The following is a description of a gene set: Genes containing one or more binding sites for (ZNF22) in their promoter regions (TSS -1000,+100 bp) as identified by GTRD version 20.06 ChIP-seq harmonization. studied in species Homo sapiens Human Gene Set: ZNF22_TARGET_GENES from publication Yevshin I, Sharipov R, Kolmykov S, Kondrakhin Y, Kolpakov F (PMID 30445619), and this is the list of marker genes: S100A2, CDH12, TPTEP2, LINC02202, SMG8, RN7SL3, ZNF419, S100PBP, PHF7, ZNF763, PTCD1, POLR3A, MT-TV, MELK, AHI1, ZNF177, CPNE1, FAM234A, DNAH14, PRR13 (proline rich 13), MT1XP1, MIR6728 (microRNA 6728), MIR4714, RBCK1, TBC1D5, RNU2-22P, MRGPRD, MIIP, OASL, UTP11, RAB26, ENSG00000224865, TRIP12, RFWD3, MAP2K5, EMX2, PUM1, MFSD2A, AHSA1, AGFG2, MIR6797, DOCK5, WFDC3 (WAP four-disulfide core domain 3), KLC4, RNA5SP492 (RNA, 5S ribosomal pseudogene 492), RPS14, RNU2-2P, GABARAP, SLC9A1, FBXL8, ATG10, MTND4LP12, SAXO5, UBE2V2P4, EMX2OS, RNU6-135P, DST, RRAS2P2, UQCRFS1 (ubiquinol-cytochrome c reductase, Rieske iron-sulfur polypeptide 1), MAPK14, IGDCC3, TNKS, PI16, ARHGAP25, KLHDC10, PPIP5K2, SGSM3, TNRC6A, LBR, CHMP6, KPNA7, ABCD4, HNRNPU, VDAC1P5, TNFRSF9, CHRNA2, RNA5SP97, ITGA8, ZNF433, GANC, RNU6-284P, COMMD4, ABCA8, KRT17P7, TPTE2P5, FLYWCH2, SERTAD4BP, C3orf62, MARS1, MICAL3, MPPE1, PRRG1, NEIL3, CLASP1, MYO19, DNAJC11, NBPF1, RPL13P4, MTRFR, CYTH1, C1orf127, TMEM14C, CYP1D1P, SLC41A2, EHMT2, HIGD2B, CELF5, SLC25A16, OSBPL8, POLR2F, XIAP, LINC02713, RPL17P47, PTCH1, CNTNAP2, TRIM23, BAX, ECT2L, EIF1AD (eukaryotic translation initiation factor 1A domain containing), LINC02185, MX2, REPS2, GATAD2B (NCBI Gene Id 57459), FOXP2 (forkhead box P2), NBEAL1, TSEN15, E2F2, CLN3, CRYZL1, FLOT1, LINC00528, EML6, LDHB, CCDC107, TIMM9, SLC25A27, LINC01766, BCL6, NR2F1, MTCO3P12, TMEM248, LINC00173, ZNF575, MAP1LC3BP1, TAF13, MFF, JPX, ETFBKMT, RPL3, MRPL36P1, RNU6-1233P, OAT, RPL7P46, CLIP2, DNAJB6, ABCA15P, MYB, TAAR5, ACTMAP, HAX1 (HCLS1 associated protein X-1), ATF7IP, RNU6-66P, GSTZ1, PKMYT1, ARHGAP17, PDE1B, ATP6V0A1, CREB3L4, TPH2, ASCC2, UBE2V1P15, EIF1AXP1, CTXND1, TACO1, ZCCHC8, EP400P1, RN7SL341P, ENSG00000262003, CFAP299, FBXW4, LINC02281, ATG13, LPP, RWDD2B, ERN2, TLR5, HMGA1P3, CCNB3 (cyclin B3), SPATS2, TMEM200A, DDX10, RNU6-199P, LINC00092, CR1L, COX6B1, ZNF295-AS1, TRAF4, PRICKLE1, LINC01926, RPS5, NFYC, ASH1L-IT1, CRYGD, NAV1, RPSA, NSL1, CCDC18-AS1, PLEKHO1, TLE2, INE1, DHRS3, TICRR, ACIN1 (NCBI Gene Id 22985), PPP1R12B, ADAMTS16-DT, UBASH3B, DYNC2LI1, TRIM11, NTNG1, ZDHHC17, APH1B, DPM3, ANXA2, IGSF9B, DCBLD1, SLX9, RNU6-1248P, SPPL2A, USP6NL-AS1 (USP6NL antisense RNA 1), MIR4477A, METTL2B, FZD9, FANCD2, SNRPD1, GON4L, EREG, TAF3, NOSTRIN, STING1, FIG4, NFKBID, RNU6-486P, LRWD1, LRRFIP1, GMPR, MUC19 (NCBI Gene Id 730517), GAS1RR, RN7SL180P, FRMD3, NVL, KATNA1, MAST1, PLXDC1, OR10G2, USP45, MRPL1, RNU6-809P, KIF23, GPATCH1, ODF2, RPS23P8, COQ9, SLC25A13, HSP90B1, YAF2, CHPT1, MPZ, ARHGEF7, PTGR1, SNAP47, KPNA6, TOP3A, RPS4X, ZNF382, CDIPT, PYDC1, RPL8, RPL26L1, INTS7, DOCK2, LINC01758, STAT6, TRAPPC2, DCTN6, NUGGC, KDM3B, USP9X, ENSG00000251126, MROH7, NCOA6, NUS1, EBF1, SNORD36B, TATDN3, IRAK4, LNCPRESS1, PRMT9, SRRM1, PPCDC, CDIPTOSP, H3C12, POLB, MORF4L2, LINC02601, INTS14, UTP18, PSMA5, EML5, MACF1, VPS51, GABRR1 (gamma-aminobutyric acid type A receptor subunit rho1), RN7SKP106, LINC02865, PPARA, FKBP10, NDUFS7, TMPOP2, IRGC, CYFIP2, SUZ12P1, ING3, HMGXB4, UBAC2, OSTCP1 (oligosaccharyltransferase complex subunit pseudogene 1), GLUD1P3, SPMIP10, RPS2P44, ATP6V0A2, A2ML1, TRAPPC13, ENDOG, ARHGEF38, EIF3J, GMNC, RPL35AP17, PAGR1, SLC35B1, TRDMT1, CELF1, H2AC17, OSBPL1A, RSRP1, OR6C75, RNU6-1, RNU6-271P, SYTL1 (synaptotagmin like 1), STMP1, P2RX4, MFN1, RN7SL40P, SLC16A1 (NCBI Gene Id 6566), SRP72P2, CAMTA2-AS1 (NCBI Gene Id 101927979), GPM6A (NCBI Gene Id 2823), CALD1, FLCN, F3, ACP6, MLIP, RN7SL67P, LINC01455, CCNC, FRMD4A, FDX1P1, C6orf52 (chromosome 6 open reading frame 52), SNHG11, NIFK-AS1, ADGRE1, PTK2B, RNU6-658P, CCSAP, ANAPC5, RNU6-760P, RC3H1, EPCIP-AS1, HOOK2, ENSG00000272195, ZNF256, ENSG00000263594, DIPK1A, H4C8, ZNF724, FCGR2A, ELF1, PDE4D, SNORD4B, TJAP1, SNORD114-19, HARBI1, CHMP4C, LINC02933, ATP5MK, PIK3R1, EVA1A, RPA2, PDCD5, KIF2C, WDR7, ABI2, LINC01547, SAFB2, FAM227B, MYNN, TPTE2, FEZF1, NLGN1, HMGN1P4, ODF4, NUCKS1, TPRG1LP1, RNU6-407P, SELENOK, GLT1D1, MPP2, CHCT1, SSBP1, ZCCHC7, NUDCD3, CDC25C, HNRNPCP9, LY6G6F, TFR2, GIT2, EML2, DNTTIP1, LINC02608, REXO4, KRT8P43, AGPAT3, NECTIN3, C19orf44, ARGLU1, LYSMD1, ZNF624, POLR1B, SNORD36A, STAG2, ITPR2 (NCBI Gene Id 3709), SKOR1-AS1 (SKOR1 antisense RNA 1), TMEM260, MT-ND4L, ZNF217, BMI1, SAT1 (NCBI Gene Id 6303), RNU6-1011P, NAGPA, RPPH1, ESRRB, SCAMP3, TEX41, HPGD, VPS53, LINC00910, TGFBR3, LYRM9, MATR3, PGRMC2, SNORD99, PLK3, SAMSN1-AS1, NR2F2-AS1, LINC01841, OR11H4, RNU6-892P, BYSL, PHLDB3, PRC1-AS1, ZEB2, PSMB10, ASB3, F5, CLTC, ZNF146, MTO1, TCF7L2, MICAL2, HNRNPH1, OPN5, LRRC3, SEPTIN2, DTD1, LRCH3, CHMP2B, LINC02219, RBM39, SIRPB2, EGFL6, SH3TC2, RPL23AP35, LCA5, LSM14A, DOCK4, ABCB11, CYCSP27 (CYCS pseudogene 27), SKIDA1, MAD1L1, LINC01596, ZNF438, TRAPPC12, VN1R20P, TADA2A, INO80D-AS1, ERICH6-AS1, ARPC3, SNHG30, VSIG10, MIR5002, LINC02371, COX6B1P2, PXMP4, DOCK7 (dedicator of cytokinesis 7), CFAP53P1, DLGAP2, AKT2, BCL11A, LIN7B, ATP5MF, SPOP, AFF4-DT, MDM1, IGLV2-8, CORO1B, BPHL, ZNF207, CACNA1A, RNF43, C17orf100, EHMT1, FUT3, FAAHP1, PIGV, ETFA, KIF21A, HNRNPD, NKAIN1, PCBD2, MIA2, TTN-AS1, CARD10, FAXDC2, EPM2A, NRP1 (neuropilin 1), H2BC11, GOLGA2P4, DNM1L (dynamin 1 like), ACSM2A, TXN2, SSBL4P, FXYD3, RNU6-375P (NCBI Gene Id 106480575), TMEM91, PSMC3IP, POLR1HASP, SNORA38, SYNM, FEZF1-AS1, F10-AS1, TAFA1, ANKUB1, STPG1, GLO1, CCDC12, RPL7A, RPS15AP29, ENOX1, GPX4, ZNF664, ST3GAL6, PLAUR, CLINT1, CRIP1P4, TPT1-AS1, SF3B4P1, KCNH5, TMEM131L, PRKCQ-AS1, DARS2, RN7SL654P, IQCE, CARM1, ADAM19, ENSG00000248367, TIAM2, CSN1S2AP, SLC7A1, CAMSAP1, GPATCH3, C20orf96, ELP3, RNU4-21P, COQ7, DNHD1, CCDC138, ADAR, ABCB10, PMM1, PDLIM2, SETDB2, HELZ, LRRIQ1, ZNF131, MIA3, ERICH6, GPLD1, ARID5A, PGAP1, USP18, GLS2, ENSG00000253205, ENSG00000255462 (novel transcript), ANPEP, FOXP1, ACLY (NCBI Gene Id 47), ANKRD39, SMIM10L1, SDCBP, SNORD42A, RPSAP53, RFXAP (regulatory factor X associated protein), TDRD9, FGD4 (FYVE, RhoGEF and PH domain containing 4), ZNF544, SLC25A30, NAALADL2, MTHFD1L, TCF20, B4GALNT2, ADI1P3, DPY19L4P2, WAC (WW domain containing adaptor with coiled-coil, NCBI Gene Id 55468), DMGDH (dimethylglycine dehydrogenase), CAPNS1, NSRP1, CHD1, GDF5 (growth differentiation factor 5), FAM174B, TMC5, FAM193A, IFI27L2, GOLM2P1, FAM177B, RNU7-65P, RPL32P26, TRGVA, TYK2, LINC02269, GSTA4, NEMF, OTOL1, TTLL13, LINC00844, PDK4-AS1, COQ2, COL12A1, SLC39A1, MAP3K7CL, MAGOH2P, GLRX5, RPL21P64, RPGRIP1, KLHL32, SNHG4, PPFIA1, MIRLET7BHG, SLC20A2, ZNF428, SULF1, PRR5L, SQSTM1, COLGALT2, RPL36AP45, TSPAN12, FAM217B, USP39, LINC01471, NAB1, TAGAP, CDH10, H3C1, EHBP1-AS1, RUFY1, HSPE1P2 (NCBI Gene Id 326300), SMG5, AAR2, FSTL4, PRPF40B, SDCCAG8, METTL5P2 (NCBI Gene Id 100419878), SEM1, RCN1P2, LTBP4, AKR1B1P2, PPP1R2P6, RPS29, RPL23A, GOLGA7B-DT, LEMD1-AS1, KCTD5, TCEA1P2, ALG1, TFCP2, UGP2, SHLD3, ADRA1A, ZNF57, SLC4A8, ACVR2A, SIRPD, WDR36, TMCO4, RPL21P128, NAA25, CDH7, NABP1, PAK1, ENSG00000229425, FAM47B, TENT2, RPS27L, TMTC1, SKIC8, LCA5L, LINC01842, LINC01553, ABR, MKNK2, DPYSL3, EEF1A1P49, GPRC5A, SFRP4, CDC42EP1, PON2, AP3B1, RBM25, RPL36AP37, UQCC6, UBE3A, CCDC163 (CCDC163 homolog), ENSG00000187951, SMG6, ATG4C, WDR89, RBMS2, DHX29, DONSON, MIER3, LLGL2, SULT1A1, SEC11A, AGFG1, LUC7L2, SPATA1, MATN4, IYD, ADK, ZBTB21, ANTKMT (NCBI Gene Id 82377), CCNE1, MBNL1-AS1, SLC25A3, PARP2, RPSAP10, SPATA6, GTDC1, GMFB, NPDC1, MT-RNR2, ZNF236, PER1, NBR1, TAF15, IFNA21, ZCCHC2, YIPF6, SERPINF1, TWSG1-DT, ULK2, RBM7, CRYBG2, LGALS8, TIMM8A, OGFRL1, ZNF677, LINC00680, SPAG9, SLC9A6, SENP7, SEC14L1, PRMT6, ARHGAP45, TMEM59, GNAS, RB1, RACK1, TCL6, SLC7A2, RPL32P3, DAB1-AS1, CHL1, ATP6V0E1P4, ZBTB8B (zinc finger and BTB domain containing 8B), SERPINB8P1, LRIG1 (NCBI Gene Id 26018), BANF1, NUP188, KRBA2, EN1, AKAP12, GAS2L3, RPL13AP2, FOXJ2, PMS2P3, NT5M, MZF1, ENSG00000259118, WDFY3, GPR85, TBKBP1, HHAT, MTCYBP43, BEGAIN, PCNX2, YDJC, TNNT1, GPBP1L1, VPS33A, RNU6-15P, RN7SL183P, LMAN1 (NCBI Gene Id 3998), MIR4795, ZNF605, SRP14, SYT11, MKI67, SNX8, GAPDHP43, RNA5SP287, IGFLR1, UCK2 (NCBI Gene Id 7371), AASDHPPT, B3GNT8, PDCD6P1, SRP68, RN7SL678P, DGLUCY, FBXO46, PKN3, VPS8, RNASEH1P2, ARRB2, MYDGF, MTMR1, WDR74, SNORD14E, MRPL9, YARS1, ERVK13-1, HCFC2, VPS11-DT, ITPRID2, SMU1P1, CUTC, UBE2D2, GCLM, FSCN1, NEGR1, C17orf75, RMND5A, TXNRD2, NKX2-5, DARS1-AS1, SIRT6, IGLV7-46, COPS4, PMCH, NFKB1, FAHD1, RPL39L, ATF7IP2, LONP2, LINC02351, CRYZP1, MTND5P11, GPR18, CEACAMP8, ZBTB22, MACROH2A1, LINC01121, PFAS, SAPCD2, CASP9, RPS27AP8, GBA1, AGPAT4, SCARNA7, SLC8B1 (solute carrier family 8 member B1), LINC02675, ZMYND19, MSI2, FBXW9, RPL7L1P12 (RPL7L1 pseudogene 12), TBL1XR1, GARNL3, NUP214, SLC7A8, DNASE1, ZNF224, NAPSA, RNU6-41P, ANKRD23, OR5A1, CP, NCSTNP1, RHOQ (NCBI Gene Id 56679), MAP2K6, DHX36, PCBP1-AS1, DOC2A, SMARCC2, SMAD7, RPL29P8 (ribosomal protein L29 pseudogene 8), CTNND1 (catenin delta 1), IPPKP1, MDH1, NT5DC1, TASOR (NCBI Gene Id 51687), MLLT10, SEMA3A (NCBI Gene Id 63232), SLITRK4 (SLIT and NTRK like family member 4), GARRE1, SPPL3, ELAC1, ZSWIM4, CHMP4BP1, BCLAF1, TMEM139, DNAH11, RERE, UGT2B4, MSTN, SUGT1P3, TRMT10B, GPR160, SNORD37 (small nucleolar RNA, C/D box 37), CBFA2T2, WDR54, JTBP1, GAS1, STK36, MYG1, ZNF696 (NCBI Gene Id 79943), LINC02828, SHROOM3-AS1, IL16, PF4, RPL26, SNORD36C, BCAS2P1, PRR14, SLC25A5P7, RNF217, EIF4E, SIN3B, TIMM44, RPSAP54, ENSG00000228919, SCARNA20, LCORL, SAR1A, CAMKK2, IDH3A, HOXB3, GTF3C1, ATP6V1E2, TNFRSF13C, PSMA6, IFIT6P, ZNF284, MAPK8IP3-AS1, PLCG1-AS1, UNKL, PDCD10, SYNE1, ABCA5, XPO6, LINC01649, LRRC27, LINC01058, DCDC2, MEIS1, COQ3, LHX8, ISLR, MVP, TCTN1, CSNK1A1P1, CYP2F1, ATP5MF-PTCD1, YY1P1, ZNF846, MT-ND4, LINC00242, DGKE, KLHL12, CMBL, HMGN2P4, BMPR1B, PIK3IP1 (NCBI Gene Id 113791), RPUSD2, RPL21P10 (ribosomal protein L21 pseudogene 10), RTRAFP1, IL2RA, GOSR1, SCYL2, SNHG8, PKIG (NCBI Gene Id 11142), PHF21A, PIGL, ABCG5, OAZ2, IGHVIII-5-1, CDK12, UBAP2, HSP90AA1, SEL1L3, WDR76, KALRN (NCBI Gene Id 8997), APOL5, STIP1, SCN3A, KRT19, HLCS, PRC1, COX6A1 (cytochrome c oxidase subunit 6A1), CEP83, BBS1, RPS15AP13, DAPK1, CARHSP1, FAM230G, RNU6-558P, MAPK9, DLG1, SERPINE3, ALG10, USP54, KDM2B, RPL17P36, RNY1P10 (RNY1 pseudogene 10), EEF2, HAGH, MIR6747, DIP2C, DOLK, MIR5582, RNU6-395P (RNA, U6 small nuclear 395, pseudogene), LINGO3, RPL7P54, DEUP1, SEPTIN7P1, TMEM150C, SUSD5, PSG11, GPR19, ENSG00000250075, UBR1, POT1 (protection of telomeres 1), SCNM1, TCF4, RPL29P27, MORF4L2-AS1, AURKC, H2AC25, USE1, ZNF689, RALGPS2, PAXBP1, AMZ2, ZMYM6 (NCBI Gene Id 9204), E2F6P4, SNORD114-29, MTND3P9, TMT1A, CTNNA1, PTPRG (NCBI Gene Id 5793), GRM7, SOCS2, IQGAP2, NMB, DNAJC2, SCUBE3-AS1, SEZ6L2, RENBP, MEF2C-AS1, LINC02028, ANKRD20A5P (NCBI Gene Id 440482), ABCC4, LINC02236 (long intergenic non-protein coding RNA 2236, NCBI Gene Id 109729133), CREM, MS4A6A, DEK, PLBD2, JMJD4, MYBPC1, SLC27A2, ERG, MAST2, RABL6, SUPT5H (SPT5 homolog, DSIF elongation factor subunit), RNA5SP321, ADCY10, SNORA73B, CCT8L1P, FAM177A1, METAP1D, LGALS3BP (NCBI Gene Id 3959), LY6G6F-LY6G6D, SPINT1-AS1, SPRED2, GARIN1B, VPS72, COQ5, THUMPD3, RPS7, RERGL, HMGCL, LINC01029, MSX2, YLPM1, NRCAM, RNU6-1024P, TCEANC, ERVH48-1, ENTR1P2 (NCBI Gene Id 650653), KRT7, KANSL3, SRRD, GRIN2A, P3H4, LINC01976, PNN, TEKT5, LNCTSI, CUX1, SUZ12 (NCBI Gene Id 23512), ENSG00000259737, FLT4, RUFY2, GLMN, ZNF573, CPB2-AS1, SLC4A7, PRPF40A, CERS2, ERCC4, TMEM9, ZNF451, BMPR1B-DT, RNU6-102P, HDAC8, PARD3, NFE2, SPECC1, CHFR (checkpoint with forkhead and ring finger domains), EPB41L3, SLC2A2, SCARNA14, C1GALT1P1, PYM1, EGFEM1P, GBA1LP, TUBA1B-AS1, DENND6A-DT, MFGE8, LINC00518, U2SURP, NUDT21, FLJ40288, CCDC47, ITGA5, NOP56P1, DOCK9, ERAP1, ALKBH4, TMEM79, TFAP4, HSP90AA5P, DZANK1, CCM2, RPL10P5, CELF2-DT, BRPF3, MTREX, SLC25A45, MYRFL, LINC02613, DEFB108B, GAPDHP65, RNF14P4 (RNF14 pseudogene 4), MIR4748, BRF1, AP2M1, RLIG1P3, NUCB2, SASH1, NOS1, CANX, LINC02225, TMEM87A, WEE1